The following is a description of a gene set: Human Gene Set: GSE43863_NAIVE_VS_LY6C_INT_CXCR5POS_CD4_EFF_TCELL_D6_LCMV_UP from publication Hale JS, Youngblood B, Latner DR, Mohammed AU, Ye L, Akondy RS, Wu T, Iyer SS, Ahmed R (PMID 23583644) CD4 T follicular helper (Tfh) cells provide the required signals to B cells for germinal center reactions that are necessary for longlived antibody responses. However, it remains unclear whether there are CD4+ memory T cells committed to the Tfh lineage after antigen clearance. Using adoptive transfer of antigen-specific memory CD4+ subpopulations (based on CXCR5 and Ly6c expression)in the LCMV infection model, we found that there are distinct memory CD4+ T cell populations with commitment to the Tfh and Th1 lineages. Our conclusions are based on gene expression profiles, epigenetic studies and phenotypic and functional analysis. The gene expression profiles of virus-specific CD4 T cell subets at effector and memory stages is presented here. species: Homo sapiens Genes up-regulated in CD4 SMARTA T cells: naïve versus Ly6c+ CXCR5+ effector during acute infection of LCMV., and this is the list of marker genes: RAB11A, ARID4A, LDHB, POLR2J2, CEP68, NRBF2, SNAPC3, ZNF516, IL17RB (NCBI Gene Id 55540), ADK, RBAK, FAM117B, FNBP1L, STXBP2, FUBP3, SPIN4, FKBP6P2, IFNA10, ENSG00000249476, AGGF1, AMMECR1, MACROD2, GVINP1, LINC02603, SLC66A3, MSH3, SCUBE2, TM4SF18, DUSP12, ALDH3A2, LINC00924, AGO2, MALT1, ZNF311, CD209, SLC25A40, STIM2, BBS10, RNF166, CIPC, PIP4P2, SLC38A9, ZNF605, VPS4B, CCT6B, ABHD12, FMO3, UPF3B, ZNF879, HLA-DPB2, PHTF2, CENPH, GJB1, TMEM200C, TBC1D24, CMTR2, ABCA8, NAF1, ZNF217, STXBP5 (NCBI Gene Id 134957), TBC1D4, MED29, ZNF347, MRPL19, LMO7, SOX2-OT, TMEM35A, LRRC8B, ENPP2, MANEA, RBKS, DACT3, PXT1 (NCBI Gene Id 222659), TMEM68, CYP2B7P, LINC00960, TRIM59, GPRASP3, TEX30, TGS1, CYB5B, LRIG2, FUT11, WBP11, GALC, YOD1, TRAM2-AS1, WASHC5, ATRN, GPATCH2, CDK8, RNF168, NPR2, RNF19A, LRRC8D, ODF4, NAP1L3, ZNF10, HNRNPU, SEC61A2, ENSG00000176984, SNX4, SETMAR, CFAP73, RPS6KA5, MAS1, UBA5, ABITRAM, CHML, MRPL35, TRMT112, COQ10A, KBTBD12, TMEM184C, NLGN1, NID1, E2F3, BUB1, TRIM23, EXOC2 (exocyst complex component 2), KLF11, NKX2-1, CENPQ (centromere protein Q), C4orf46, OLFM4, ZNF137P, OXR1, POLR1F, C1GALT1, HSDL1, ACSM3, CENPK, GTF2IRD1, BRD1, FKBP3, MOCS3 (NCBI Gene Id 27304), TMEM8B, ARRDC4, DACH1, ZNF826P, ZNF891, HPCAL1, GPRASP1 (NCBI Gene Id 9737), FRY, CDC23, CYP4X1, ARF6, THNSL1, ZNF576, POLR2D, H2BC12, NRK, DVL3, RAPGEF6, B3GALNT2, LXN (NCBI Gene Id 56925), TAF2, NRG3, TNRC6B, HSD17B11, C2orf76, TXNDC16, PCCB, CBX1, RUFY2, TERF1, HAUS1, DDHD1, BBS12, HELLS, NECTIN3, TP53RK, MBTD1, KYAT3, QSER1, PCLAF, UBTF, PRIM2, BMPER, ISCA2, QRSL1, NPEPPSP1, ATP7A, RMND1, PRDM5, METTL14, MARS2, AFAP1, ELF5, CCSER2, ACMSD (NCBI Gene Id 130013), ANOS1, SPATA4, CFAP96, XPOT, TMA16, CIDEB